The following is a description of a gene set: Genes predicted to be targets of miRBase v22 microRNA hsa-miR-4470 in miRDB v6.0 with MirTarget v4 prediction scores > 80 (high confidence targets). from publication Chen Y, Wang X (PMID 31504780) Human Gene Set: MIR4470 species: Homo sapiens, and this is the list of marker genes: CCSER1, SLC44A2, DELE1, RARG, GPC6, PRTG, GNB1, C1QL3, SLC7A1, CERT1, CASK, HIPK3, LTN1, PTEN, XPR1, SOX6, IFNW1, FRS2, ARHGAP6, SSH2, SRF, SLC30A1, IL18R1, LRRC55, PTER, OTUD6B, NAMPT, COMMD3-BMI1, PSME4, LTV1, GRID2, CPSF7, NCAPD2, MBNL1, TARBP1, NOTCH2, PIK3AP1, FBXW11, FOXO1, ABHD13, FAM78B, PDE5A, AKAP13, AXIN2, RAB2A, PLPPR2, FBXW7, AZIN1, KCNE4, HIGD1A, SLC9A7, UGT3A2, CHSY1, PHF21A, NUP58, HSPH1, RETREG1, BBOF1, BBX, CEP83, NF1, A1CF, WIPI2, RAB3B, SREK1, BCL2L12, SLAIN1, MORN2 (NCBI Gene Id 732175), EML1, DOCK10, SNX4, NUP98 (nucleoporin 98 and 96 precursor), RWDD3, SH3KBP1, FOXF2, CCT8L2, CCDC125, ARMC1, COL1A2, DNAJB14, SLC39A9, ZC3H15, KLF11, TRUB1, CCNY (cyclin Y), PRDM10, WDR82, DMXL1, ZMAT3, DERL2, RIMKLA, EYS, NFYC, CACNB4, PTP4A1, ARL6IP5, RWDD2A (RWD domain containing 2A), IKZF5, MYO1C, FBXW2, EBF3, ARID4B, MTHFD1 (NCBI Gene Id 4522), SNX19, ASCC3, PRR27, QSER1, CDC42, PLEKHA3, PDE7A, SCN7A, SORL1, CD47, ADD3, SEC22A, TACC1, CELF2, TAGAP, KHDRBS2, FAM81A, BET1, CAMK2D, TNS3, PRKAA1, UBAC2, SERTAD4, ALCAM, TRIO, TP63, RNF208, CBFA2T3, SETX, APLN, CTTN, AP3M1, SCN9A, CLASP1, CNOT2, ST13, IRF2BPL, VAMP1, ATP9A, PRKACB, ZXDB, UNC13C, ADRA2C, KCNH8, MPZL3, RALGAPB, FPR3, BMI1, ARPP21, C5orf15, IL20RA, KLHL31, PPP3CB, PAPPA, CADM2, SORBS2, SORT1, GATAD2A, CCDC178, MCPH1, HACE1, FBXL12, ATF6, COL5A2, CAMSAP2, CACNG1, COBL, RPRD1B, TBC1D25, PCNX1, MYO1D, CATSPERE, HOXA9, PPM1K, NFE2L1, ATP5MC3, CDHR3, ZNF445, SEPTIN9, AGMO (NCBI Gene Id 442510), TULP3, STK39, GATA3, MECOM, USP13, AP3S1, RPL32, SKIL, ROCK1, BTRC, FIGN, CREBRF, ATP8A1, DENND1B, PYGO2, CALN1, PRUNE2, ELL2, REV3L, SLC35D1, NCOA7, NPTX1, BRWD3, JPH3, NRN1, RABGEF1, MAGED2, NCALD, PRKAR2A, STX17, DENND4C, LHX8, PMP2, GNB4, EVI5, MAPK7, MAGI2, WNK3, ELL, LIMS1, PTPRD, EGLN1, RAB10, PTPRG, LAMC1, MAN1A1, CYLD, FAM174B, MECP2, ENTPD1, YWHAG (NCBI Gene Id 96443), TOR1B, OSTF1, ZNF501 (zinc finger protein 501), WDR37, SNX6, HS6ST2, RERG, ATP6V1H, MKX, PAN3, IGSF10, CUL5, UHMK1, CACNA2D3, SERINC5, TBC1D12